The following is a description of a gene set: studied in species Homo sapiens Human Gene Set: GOBP_REGULATION_OF_CELL_CYCLE_PROCESS Any process that modulates a cellular process that is involved in the progression of biochemical and morphological phases and events that occur in a cell during successive cell replication or nuclear replication events., and this is the list of marker genes: NUF2, PRPF40A, ACTB, CHMP7, PPP2R1A, GPR15LG, TERF2, DAZL, WDR76, CHMP4A, RCC2, KIF2B, BUB1, STOX1, TAOK1, ABRAXAS1, ATXN10, TAOK3, ZNHIT1, RAB6C, PPP1R10, RAD51 (RAD51 recombinase), MEPCE, ANAPC11, RAD51C, DRG1, TNF, CDKN1A, DONSON, MNAT1, GFI1B, PAXIP1 (PAX interacting protein 1), INHBA, MIR638, RPA4, MKI67, POC1A, CENPE, RBBP8, MIR515-1, MIR193A, ANAPC1, INSR, CEP295, RNASEH2B, FGF10, PAF1, PRMT5, KIF11, INTS3, SLFN11, RAD18, LYN, USP44, CCAR2, SPDL1, RASSF1, DOT1L, CCL2, CDK2, LRP5, KIF20B, PABIR1, EIF4G1, MAPK14, PIN1, AXIN2, MIR221, ZNF830, OBSL1, WNT4, PRMT2, PLK4, NEK11, FBXO6, PDCD6IP, ECT2, BRIP1, NCAPG, RINT1, L3MBTL1, STK38, MED1, OOEP, ANKK1, LSM11 (NCBI Gene Id 134353), CDK7, PTPN11, RRM2B, NCAPG2, MIR372, AURKC, FEN1, MSH2 (NCBI Gene Id 8169), FOXN3, EML3, SOX15, DCDC1, KLHL13, DPF1, CDKN2A, RAE1, RCC1, SH2B1, HECW2, ERCC2, CCDC15, PRDM9, CHMP1A, PLK5, RAD9A, CDC14B, EDN3, MIR16-1, LCMT1, SMARCA2, DDR2, FANCD2, ATRX, FBXW5, FSD1, SIRT2, INS (insulin), BRSK1, ATAD5, ACTL6A, ANKRD31, RGCC, SPC25, CENPF, MYBBP1A, SMARCD1, DTX3L, PLSCR1, FAM83D, NUGGC, CLOCK, PINX1, DYNC1LI1, PLK2, CEP85, CUL4A, BLM, RPRD1B, FBXO4, LSM10, SUSD2, CEP250, KANK2, TRIAP1, DACH1, UBXN2B, ANAPC7, GIT1, TAOK2, TMEM67, SND1, ANAPC4, MIR133B, ACTL6B, BRCC3 (BRCA1/BRCA2-containing complex subunit 3), MAD2L1, PDE3A, KMT2E, ZFP36L2, EGF, TNKS, CDC14C, MIR195, RFPL1, CDK14, MTBP, NPM2, PSME3, TGFA, TAF1, IK, SETD2, ETAA1, EREG, TICRR, SIN3A, NANOS2, PROX1, RNF4 (NCBI Gene Id 6047), CEP131, MAPK15, ZWINT, FZR1 (NCBI Gene Id 8855), STIL (NCBI Gene Id 6491), SMC5, PSME2, CDC16, FGF8, TMOD3, RRM2, BABAM1, RXFP3, CDC20, ADAM17, CEP76, SMARCA5, ENTR1, CDC5L, GLI1, WAC, RAD9B, PUM1, APPL2, SMC2, DRD3, RAD21, ARID1A, BECN1, ERCC3, FBXO43, SPAST, CDK15, MAD2L2, HINFP, BCL7A, E4F1, CHMP4BP1, BIRC6, CDC27, HSPA1B, CDK11A, ECD, RDX, MOS, MUC1, MAP3K20, MN1, SLF2, MIR520H, TPR, TIPIN, KNTC1, CDK5RAP2, CHMP2A, CHMP3, PLRG1, BAZ1B, CDK5RAP3, BRD7, ROCK2, MAP10, HASPIN, PDXP, TFDP3 (NCBI Gene Id 51270), EDN1 (endothelin 1), MIR133A1, MRGPRX2, ARF6, HUS1, APC, MDC1, CCND1, DYNC1H1, DAB2IP, MIR362, BRCA1, ATR, ZNF16, FGFR1, CDC45, KLHL22, DBF4B, NUP62, WEE2, CDC25A, CHMP5, DUSP1, POC1B, USP50, BABAM2, ALMS1, JADE1, ZC3H12D, WDR62, TPX2, TP63, KLHL9, BUB3, FEM1B, MIR10A, CCNL2, BORA, UVRAG, CDC23, SMARCE1, PPP2R5B, PHF10, STXBP4, CTDSP1, SVIL, MARK3 (microtubule affinity regulating kinase 3), NUDT16, PRKDC, KIF13A, ZNF655, EZH2, OR1A2, PKD1, MIR495, BUB1B, ANAPC2, DAPK3 (NCBI Gene Id 1613), TP53BP1, HEXIM2, CDC25C, ACVR1, MIR892B, ING4, PARP3, BCL2L1, SFPQ, CTNNB1, TTI2, FBXO7, CEP97, NABP2, E2F8, CTDSP2, KNL1 (NCBI Gene Id 57082), PLK1, RAB11FIP3, BMP7, TBX20, ARID2, IHO1, RFWD3, CHMP6, CDK4, SH3GLB1, CEP295NL, STK33, PTEN, NSMCE2, CEP120, PLK3, AURKB, CSNK2A1 (NCBI Gene Id 1457), CDC6, UBE2C, CDKN2C, SKA3, MSX2, MIR137, DYRK3, SETMAR, CACNB4, CSNK2A2, MIR503, RMI2, WNT5A, STK35, SMARCD2, RIOK2, IER3, PRPF19, BCL7B, RAD50, CYP1A1, TGFB1, ATF2, CTCF, PKP3, TOM1L2, RBM14, DPF3, MIR519D, ERCC6, SSTR5, SASS6, TFAP4, CSPP1, CAV2 (NCBI Gene Id 858), NAE1, MIR26A1, MRE11, SMC4, PPP1R9B, DLGAP5, TOM1L1, MIR15A, CDCA2, PLCB1, PSMA8, YTHDF2, DRD2, APBB2, CDC42, MRNIP, CCDC8, MSX1, AHCTF1, UBE2E2, KLHL21, TOPBP1, CDK5, GPR132, DPF2, BRD4, TAS2R13, EME2, BCL7C, MIR214, NCAPD3, NUBP1, NCAPH, PPP2CA, MIR520A, TACC3, NEK2, MYO16, PKN2, CDK16, PRC1, RHOA, PIK3R4, ATP2B4, MBLAC1, INO80 (NCBI Gene Id 84156), MDM1, ZFYVE26, CDCA8, FBXO5, RAD1, CEP63, ANKRD17, CDK2AP2, DCTN1, CHEK1, AURKA, GPR3, UFL1, RBL2, PSRC1, NUSAP1, TIMELESS, AMBRA1 (NCBI Gene Id 55626), KLHL18, SPICE1, HNRNPU, CHMP1B, ANLN, KCNH5, CTC1, PHIP, MUS81, SMARCB1, BBS4, EXOC7, ANKRD53, MIR29B1, PPP2R2A, UIMC1, MIR222, SYF2, CCNH, INSM1, CCNE2, IGF2, CALM1, GPNMB, ZMPSTE24 (NCBI Gene Id 10269), CAMSAP3, DDX11, EPGN, CDK11B, TMSB4X, LIF, CLTC, BCL2, MIIP, MBTPS1, STRA8, ANXA1, MTA3, GPER1, PPP2R2D, TRIM39, KAT2B (NCBI Gene Id 8850), WEE1, SIRT1, MIR21, CCSAP, PUM2, SMARCA4, WNT10B, TCF3, RRP8, CALM3, CDKN2D, TERT, USP19 (NCBI Gene Id 10869), HORMAD1, DUX4, CHFR, XPC, WIZ, CDK10, CCNB1, UBE2B, RAB11FIP4, BRCA2, ATF5, BIN1, RPTOR, UBD, PSMG2, CDC7, PKHD1, MACROH2A1, C9orf78, AURKAIP1, NDC80, SMC6, PRAP1, PDGFRB, KIF23, PRP4K, KIF20A, HSPA1A, DLG1, CHMP2B, TERF1, CENATAC, TMEM14B, PKP4 (plakophilin 4), MLF1, PTPN6, NAT10, EGFR, AVEN, INTS7, CDC14A, DTL, CENPV, MAGEA5P, MCPH1, AIF1, OPN1MW2, H2AX, TEX14, NANOGP8, NEK6, GNB1L, ZFYVE19, PBRM1, APPL1, CDC73, PTENP1-AS (PTENP1 antisense RNA), KIF3B, INCENP, FBXO31, MEIOSIN, NCAPD2, DDB1, SPAG5 (NCBI Gene Id 10615), PKD2, CXCR5, SMARCC1, TRIM37, NEK10, MIR29C, DCUN1D3, PKIA, PIWIL2, LEF1, TCIM, ARID1B, BTN2A2, SKA1 (spindle and kinetochore associated complex subunit 1), MAD2L1BP, MAD1L1, CDKN1C, CUL3, CCNQ (cyclin Q), CDK3, MDM2, AKT1, CRLF3, CCNL1, DDX3X, RB1, BMP4, NOP53, USP51, PAGR1, PBX1, MAP9, RPL23, VPS4A, PARP9, E2F7, SENP6, RPS6KA2, ID2, CUL9, KCNA5, XRCC3, MIR451A (microRNA 451a), CCND3, CIT, CALM2, NSUN2, ESPL1, NEUROG1, ENSG00000266560, PSME1, DACT1, RACGAP1, DDRGK1, CALR, MYC, IGF1, DNA2, KIF14, IL1A, WAPL, CENPJ, TAS1R2, CDK1, ZFP36L1, NPR2, FBXW7 (F-box and WD repeat domain containing 7), MIR19B1, CDCA5, TXLNG, TTI1 (TELO2 interacting protein 1), RAD51AP1, GNAI1, KLF11, SMPD3, CDT1, NME6, NUMA1, CHMP4C, BTC, CRNN, SDE2, NAA10 (N-alpha-acetyltransferase 10, NatA catalytic subunit), EIF2AK4, RAB11A, NCAPH2, TP53, SENP2, CDKN1B, SMARCC2, SFRP1, TIPRL, MARK4, RAD17, BIRC5, ANAPC5, KIF25, PRKCE (protein kinase C epsilon), SOX2, CCNE1, RPS27L (NCBI Gene Id 51065), OVOL1, KAT5, ATRIP, CUL4B, NFE2L1 (NFE2 like bZIP transcription factor 1), CDC25B, CPSF3, MIR30C2, TTK, WNK1, CDK18, RAD51B, DMRT1, SOX9, CHMP4B, OPN1LW, CETN2, TREX1, C10orf90, SIX3 (NCBI Gene Id 6496), CHORDC1, CCDC66, HLA-G, KIF2C, TPRA1, TFDP1 (NCBI Gene Id 7027), PDIK1L, FAM107A (family with sequence similarity 107 member A), ORC1, MIR873, E2F1, AICDA, KNSTRN, IL1B, MBTPS2, PPP1R35, POLDIP2, PHOX2B, GPSM2, RIPOR2, ZW10, CDK17, CD28, OPN1MW, EME1, CHEK2, VPS4B, ADAMTS1, BID, ZWILCH, RANBP1, RPA2, POC5 (POC5 centriolar protein), FOXO4, APBB1, GEN1, PKMYT1, ZNF207, SPHK1, CUL7, CCND2, NABP1, KAT2A, SLF1, MIR424, HMGA2 (NCBI Gene Id 8091), GIPC1, MYO19, CCNF, TELO2, DBF4, USP28 (NCBI Gene Id 57646), FHL1, MIR208A, GIGYF2, DGKZ, CLSPN, GTPBP4, NBN, MIR29A, INSM2, CDKN2B, CTDSPL, BARD1, CRY1, NSFL1C, RHNO1, USP17L2, HSPA2, ATM, CCP110, PDGFB, CDK6, XPO1, BCL6, PIK3C3, HOXA13, RRM1, TRIP13, RBL1, MIR15B, OR2A4, SPC24, INIP, PLCG2, SMARCD3, NPM1, ANAPC15, TBX2, TM4SF5, KLF4, HUS1B